Given this list of marker genes CHMP3, BORCS7, SNAPIN, BORCS6, BLOC1S2, BORCS8, RAB5A, ALS2, BLOC1S1, KXD1, BORCS5, here is a description of the gene set: Any process that modulates the volume of an endosome, a membrane-bounded organelle that carries materials newly ingested by endocytosis. studied in species Homo sapiens Human Gene Set: GOBP_REGULATION_OF_ENDOSOME_SIZE